The following is a description of a gene set: Human Gene Set: ZHONG_PFC_C6_DLX5_GAD1_GAD2_POS_INTERNEURON from publication Zhong S, Zhang S, Fan X, Wu Q, Yan L, Dong J, Zhang H, Li L, Sun L, Pan N, Xu X, Tang F, Zhang J, Qiao J, Wang X (PMID 29539641) studied in species Homo sapiens, and this is the list of marker genes: RBP1, ARX, DLX2, PFN2, GAD1, BRINP2, ID2, ERBB4, ARRDC3, MAF, PDE4DIP, DLX5, ACKR3, GAD2, NXPH1